The following is a description of a gene set: Human Gene Set: REACTOME_PROCESSIVE_SYNTHESIS_ON_THE_C_STRAND_OF_THE_TELOMERE Processive synthesis on the C-strand of the telomere studied in species Homo sapiens, and this is the list of marker genes: POT1, RPA1, ACD, BLM, LIG1, PCNA, TERF2, POLD3, POLD1, TERF2IP, WRN, TINF2, RPA2, TERF1, RPA3, DNA2, POLD2, FEN1, POLD4